Given this list of marker genes RAB35, TUBB8, FAM83D, SETX, ADRB2, FKBP6, RMDN3, TRIM45, PYCR3, HSD3B1, ANAPC7 (NCBI Gene Id 51434), DUSP11, PCIF1, RPGRIP1, MICAL1, TUBB6, RFXANK, TUBB4B, NCAPH2, MTUS2, SEPTIN9, RBM18, KMT5B, RAB11FIP3, HAUS3 (HAUS augmin like complex subunit 3), FAN1, DZIP1L, PARP3, KIF20A, PPP1R13L, NUPR1, KCNV1, SNRNP25, UNC119, PHLPP2, KLHL22, CDCA8, CEP131, DNAJC8, HNF4G, CYTH4, APC2, JPT1, SPESP1, PRC1, CD34, SEPTIN2, USB1, DCTN1, NISCH, KLHDC8B, AAMP, CENPE, MICAL3, OLFM4, FLNC, GSTM4, CHRNA2, HSD3B2, ESRRA, TUBB, TMEM9, TEX14, KIAA1671, GSTM2, DNALI1, KIF20B, EPB41, KLK6, IFT88, FAM50B, NEK2, NGRN, RBM44, TUBB2A, TPX2, CDC6, PIK3R4, WAPL, TUBB3, ARL13B, NUDCD2, AOX1, PRKCI, SRA1, TUBB8B, ACOT12, GSTM3, TUBB1, EML4 (NCBI Gene Id 54548), KICS2, TUBB2B, GSTM5, EAF1, IFT43, PKNOX2, SKA1, CDC7 (NCBI Gene Id 8317), GPX2, TUBB4A, CEP55 (centrosomal protein 55), GSTM1, KRR1, here is a description of the gene set: species: Homo sapiens Human Gene Set: GOCC_INTERCELLULAR_BRIDGE A direct connection between the cytoplasm of two cells that is formed following the completion of cleavage furrow ingression during cell division. They are usually present only briefly prior to completion of cytokinesis. However, in some cases, such as the bridges between germ cells during their development, they become stabilised.